The following is a description of a gene set: Human Gene Set: GOBP_CELL_CYCLE_G2_M_PHASE_TRANSITION species: Homo sapiens The cell cycle process by which a cell in G2 phase commits to M phase., and this is the list of marker genes: FBXL15, AURKA, BRD4, SYF2, DNM2, PINX1, MTA3, CTC1, PDIK1L, NABP2, NDC80, BRCC3, CCND1, ZNF830, RRM2B, UBE2A, ARPP19, CDC7, PLK3, CDKN1A (cyclin dependent kinase inhibitor 1A), CDC14B, PABIR1, AVEN, MIR19B1, AURKB, FOXN3, LCMT1, TRIM39, TAOK3, USH1C (USH1 protein network component harmonin), CDC6, MBTPS2, CDC25C, PLK1, CDK5RAP3, VPS4B, BABAM2, PBX1, AKAP8, NAE1, MIR195, CCNA2, FOXO4, MASTL, CDK10, RAD51B, ZFYVE19, CALM3, CHEK2, BRCA1, USP17L2, FZR1, MRNIP, CDK3, ABCB1, USP50, MRE11, CHMP4C, DYRK3, PHOX2B, RAD17, DTL, RAB11A, ORC1, CDK6, TOPBP1, BRSK2, WEE1, HUS1B, DONSON, TPD52L1, INTS3 (NCBI Gene Id 65123), KDM8, RAD51C, KCNH5, BLM, CDC25B, CDK2, CDC25A, RBBP8, TICRR (TOPBP1 interacting checkpoint and replication regulator), INIP, HSPA2, WNT10B, SMARCD3, NEK10, PPME1 (NCBI Gene Id 51400), NBN, CLSPN (claspin), SKP2, STOX1, RNASEH2B, CHFR, HUS1, ATF5, VPS4A, FHL1, ATM, CCDC57, BABAM1, RINT1, DBF4B, USP22, RCC2, CENPF, RAD50, PKIA, CDK1, KIF14, NABP1, LATS1, GTPBP4, UIMC1, PLCB1, RAD21, CHEK1, TAF2, CCNQ, SIN3A, KHDRBS1, MARK3, FOXM1 (NCBI Gene Id 2305), ABRAXAS1, CCNY, BRSK1, TP53, FBXO5, PKMYT1, ATAD5, MACROH2A1, MBTPS1, STK35, FBXL7, ING4, CCNB2, PAXIP1, BARD1, ATR, TAOK1, NES, CCNB1, ENSA, CDK4, GPR132 (NCBI Gene Id 29933), CALM2, MELK, CDK14, DBX2, ETAA1, IER3, MIIP, RFPL1, TAOK2, NOP53, PPM1D, BIRC5, NPM1, HEXIM2, AKAP8L, RRM1, CALM1